Given this list of marker genes Usp8, Nedd4, Rnf19a, Mdm2, Cdh1, Fbxo2, here is a description of the gene set: Mouse Gene Set: GOBP_REGULATION_OF_PROTEIN_CATABOLIC_PROCESS_AT_POSTSYNAPSE_MODULATING_SYNAPTIC_TRANSMISSION species: Mus musculus Any process that modulates synaptic transmission by regulating a catabolic process occurring at a postsynapse.